The following is a description of a gene set: species: Homo sapiens Human Gene Set: chr4p13, and this is the list of marker genes: SLC30A9, TMEM33, APBB2, ATP8A1, ATP1B1P1, ENSG00000250781, GRXCR1, SHISA3, OR5M14P, LINC02383, ENSG00000289643, BEND4, KCTD8, UCHL1-DT, RNU1-49P, RPL12P20, LINC00682, PHOX2B-AS1, LINC02475, RN7SL691P, UCHL1, RN7SL193P, RPS7P7 (ribosomal protein S7 pseudogene 7), PHOX2B, RN7SKP82, NDUFB4P12, HMGB1P28, LIMCH1, ATP8A1-DT, DCAF4L1, CCNL2P1